Given this list of marker genes DKK1, FZD5, WNT2B, ROBO2 (NCBI Gene Id 90370), ROBO1, C12orf43, HOXA11, FGF1, GATA5, GDNF, FGF10, BMP4, SPRY1, SOX8, MESP1, SOX9, SIX1, WNT4, HIPK1, BMP2, NKX2-1, FGFR1, SALL1, FGF8 (NCBI Gene Id 2253), HOXC11, AR, CTNNB1, WNT3, FRS2, WNT1, SIX3, HIPK2, POU5F1, FGF2, WNT2, here is a description of the gene set: A developmental process involving two tissues in which one tissue (the inducer) produces a signal that directs cell fate commitment of cells in the second tissue (the responder). Human Gene Set: GOBP_DEVELOPMENTAL_INDUCTION studied in species Homo sapiens